The following is a description of a gene set: Triggering of B cell receptors (BCR) induces a massive synthesis of NFATc1 in splenic B cells. By inactivating the Nfatc1 gene and re-expressing NFATc1 we show that NFATc1 levels are critical for the survival of splenic B cells upon BCR stimulation. NFATc1 ablation led to decreased BCR-induced Ca++ flux and proliferation of splenic B cells, increased apoptosis and suppressed germinal centre formation and immunoglobulin class switch by T cell-independent antigens. By controlling IL-10 synthesis in B cells, NFATc1 supported the proliferation and IL-2 synthesis of T cells in vitro and appeared to contribute to the mild clinical course of Experimental Autoimmune Encephalomyelitis in mice bearing NFATc1-/- B cells. These data indicate NFATc1 as a key factor controlling B cell function. Human Gene Set: GSE21063_CTRL_VS_ANTI_IGM_STIM_BCELL_16H_UP from publication Bhattacharyya S, Deb J, Patra AK, Thuy Pham DA, Chen W, Vaeth M, Berberich-Siebelt F, Klein-Hessling S, Lamperti ED, Reifenberg K, Jellusova J, Schweizer A, Nitschke L, Leich E, Rosenwald A, Brunner C, Engelmann S, Bommhardt U, Avots A, Müller MR, Kondo E, Serfling E (PMID 21464221) species: Homo sapiens Genes up-regulated in B lymphocytes: control versus stimulated by anti-IgM for 16h., and this is the list of marker genes: PPP1R14C, POLE2, EIF4E, TMEM263, UBE2C, TIPIN, NARS1, KIF23, BIRC5, CLDND1, CCT5, BHMT, ABHD11, PRC1, RNASEH2A, STRBP, SKA2, TMEM161B, CDK1, VRK1 (NCBI Gene Id 7443), CDT1, PTPN5, KIF20B, TXNDC5, LSM3, MIS18BP1, TAF15, CBX5, RPA3, CCDC30, EXPH5, TPI1, IFI30, CSF2RA, FADS1, C9orf72, CCNA2, C1QBP (NCBI Gene Id 708), FLRT3, INTS12, CENPN, PGAM5, TIMELESS, TICRR, AGFG2, CNTROB, EMC1, SLC49A4, TMCO6, AATK, MTHFD2, PSTK, CENPU, SPAG5, DBP, SDHAF3, CDR2, SLC7A5, ZFP82, TMEM191C, KMT5A, RBBP4, NEIL1, IDH2, TFPI, DNMT1, SLC9A5, ZCCHC8 (NCBI Gene Id 55596), NVL, MIPEP, CENPE, TNFAIP1, IFT140, MCOLN2, TRIM68, ARC, CKAP2, KRTAP26-1, PSD2, RACGAP1, CDKN3, GPSM2, RAD51B, RCOR3, RASGEF1B (RasGEF domain family member 1B), ST6GALNAC1 (NCBI Gene Id 55808), CIB2, KYAT3, RAB12, CD2AP, NDC80, TOP2A, CACNA1S (NCBI Gene Id 779), NECTIN2, PLPPR2, DET1, TFRC, ALDH1L2, ERO1A, SNRPF, HP1BP3, ICE2, ATXN7, PUS10, HDDC2, CCNB2, NEUROG3, CCDC63, EBF1, FKBP1B, KNSTRN, STN1, DNMT3B, MDM1, AURKA, TERB1, KDSR, PRSS37, ASRGL1, SERPINB1, LPP-AS2, NAP1L1, GRK6, SLC6A15, MRPS33, SGIP1, IDH3B, VAV1, CEP55, CEP76, CCDC85A, GPR180, PCK2, CCDC120, SLFN12, TRIM28, MTMR7, NRM, ORC2, DPF1, HR, HYI, GPAM, BBOX1, TUBGCP5, HNRNPDL, PRR5 (NCBI Gene Id 86335), ECT2, SOSTDC1, CEP57, MORF4L2, AKR1B1, STK33, RAPGEF5, CDC25C, TNFRSF10A, VPS72, KCNB1, FBXO5, KIF20A, HMGCL, CRHBP, TBC1D24, HAUS6, DLGAP5, GPR85, SNRPA, SGO1, ATF3 (NCBI Gene Id 467), STT3A, TMEM88, BORA, IPO11, IFITM2, CLIC4, CXCR6, GFRA1, PRKCI, FKBP7 (NCBI Gene Id 51661), RNF26, SELENOH, IL17A, CHCHD10, LCA5, SMUG1, ARMH3, DLL4, MAOA, SPC24, ASXL2 (ASXL transcriptional regulator 2), RBBP9, SLC25A28 (solute carrier family 25 member 28), ASPM, CRLS1, MMS22L, PRR11, MTFR2, SEMA6D, ARHGAP33